Given this list of marker genes Ptger3, Rasd2, Glp1r, Gipr, Dgkq, Pde8a, Gm527, Adcyap1, Adcy2, Insl3, Pde4b, Pde6b, Ghrh, Pde2a, Pde4d, Mgrn1, Pde1c, Pde1a, Oprl1, Cgas, Adcy8, Gapdhrt2, Gal, Ucn, Sox9, Taar1, Epha5, Pde1b, Lpar1, Ahr, Pebp1, Cdc34, Pde5a, Gnai1, Pde7a, Pde9a, Npy2r, Pde10a, Pde6c, Pde3a, Cap1, Cdc34b, Ptger4, Rapgef2, Oprm1, Pde8b, Gpr3, Pde4a, Pde6a, Aplnr, Sct, Pde4c (phosphodiesterase 4C, cAMP specific), Gip, Ube2b, Ghrhr (growth hormone releasing hormone receptor), Pde11a, Cap2, Chga, Sctr, Gapdh, Pex5l, Crhr2, Nucb2, Pde3b, Crhr1, Pde7b, Adcyap1r1, Adgrg6, Ece1, Crh, Rxfp2, Gapdhrt, Adora2b, here is a description of the gene set: Mouse Gene Set: GOBP_CAMP_MEDIATED_SIGNALING studied in species Mus musculus An intracellular signaling cassette that starts with production of cyclic AMP (cAMP), and ends with activation of downstream effectors that further transmit the signal within the cell.